The following is a description of a gene set: studied in species Homo sapiens Human Gene Set: chrXq21, and this is the list of marker genes: RPS6KA6, CALM1P1, HNRNPH3P1, LINC03077, MIR548M, UBE2V1P9, ENSG00000252016, VDAC1P1, GTF3C6P1, KLHL4 (kelch like family member 4), KPNB1P1, ENSG00000289132, MIR4328, NDUFB5P2, SRIP2, RPS7P13, UBE2DNL, TUBB4BP8, SERBP1P4, CTHRC1P1, HMGN1P34, RPL22P22, RNU6-555P, MIR361, MIR384, MIR325, RN7SL460P, ATP7A, BRWD3, WBP11P3, MAGT1, MIR548I4, POMPP1, HDX, RNA5SP510, DLGAP5P2 (DLGAP5 pseudogene 2), ITM2A, SATL1, TMEM184CP1, TBX22, P2RY10, APOOL, RPA4, HK2P1, CHM, FABP5P15, PCDH11X (NCBI Gene Id 93452), CYSLTR1, RNU6-854P, P2RY10BP, RN7SL74P, ZNF711, SH3BGRL, ENSG00000289575, CHMP1B2P, TGIF2LX, KIF4CP, RNU6-974P, RN7SL379P, RPL34P36, LPAR4 (NCBI Gene Id 2846), RPL6P29, C4orf46P2, MIR325HG, GEMIN8P3, EIF3JP1, FAM133A, DACH2 (NCBI Gene Id 117154), EIF3MP1, DIAPH2-AS1, RPSAP15, SETP4, PGK1, STIP1P3, COX7B (cytochrome c oxidase subunit 7B), RNU2-26P, PABPC5, EEF1A1P29, AP2B1P1, MIR1321, NAP1L3, TERF1P4, RNU6-332P, KRT18P11, SNX3P1X, RNA5SP509, NCKAP1P1, RPL26P36, FCF1P9, SPRYD7P1, UBE2V1P7, RNF19BPX (NCBI Gene Id 100419789), RPS29P28, VDAC1P3, ENSG00000233887, ENSG00000202183, COPS8P1, PSMA1P1, SKP2P1, RN7SKP194, CAPZA1P1, CPXCR1, CCNB1IP1P3, RTL3, CORO1CP1, PPATP2, ST13P18, NDUFA5P7, RPL7P54, RPL7P55, POU3F4, RNU6-995P, ATRX, FNDC3CP, HNRNPDLP3, PDK1P2, EIF4A1P10, NT5DC1P1, SFR1P2, PABPC5-AS1, PAICSP7, USP12PX, FGF16, TAF9B, PGAM4, TENT5D (terminal nucleotidyltransferase 5D), ENSG00000239008, HMGB1P32, EEF1A1P15, TUSC2P2, STAU2P1, BRDTP1, DIAPH2, RNU6-493P, GPR174, TPMTP4, USP37P1, HMGN5, POF1B, MRPS22P1, KAT7P1, ATG4AP1, CYLC1, HNRNPDLP1